Given this list of marker genes Col4a1, Col5a1, Col4a3, Col9a1, Col2a1, Col6a6, Col5a2, St8sia4, Col6a3, Col9a2, Col4a5 (NCBI Gene Id 12830), Col5a3, Col4a4, St8sia2, Col9a3, Col6a1, Col3a1, Col6a5, Col6a2 (NCBI Gene Id 216121), Col4a2, here is a description of the gene set: Mouse Gene Set: REACTOME_NCAM1_INTERACTIONS studied in species Mus musculus NCAM1 interactions